Given this list of marker genes Mettl4, Lig3, Ssbp1, Atg7 (NCBI Gene Id 74244), Mtnap1, Endog, here is a description of the gene set: Mouse Gene Set: GOBP_REGULATION_OF_MITOCHONDRIAL_DNA_REPLICATION Any process that modulates the rate, frequency or extent of the process in which new strands of DNA are synthesized in the mitochondrion. studied in species Mus musculus